The following is a description of a gene set: Mouse Gene Set: GOBP_REGULATION_OF_PROTEIN_TARGETING Any process that modulates the frequency, rate or extent of protein targeting. studied in species Mus musculus, and this is the list of marker genes: Gdi1, Nucb1, Kcne1, Mief2, Hras, Prnp, Bag4, Kcnb1, Mief1, Cacnb3, Adcy10 (NCBI Gene Id 73777), Srebf1, Inpp5k, Actr3, Cdkn2a, Pdcd5-ps, 4930550C14Rik (NCBI Gene Id 75311), Slc51b, Tomm70a, Fbxw7 (F-box and WD-40 domain protein 7), Fis1, Pak1, Lrrk2, Tent2, Tomm7 (NCBI Gene Id 66169), Atp5if1, Pdcd5, C2cd5, Siah3 (NCBI Gene Id 380918), Cib1 (calcium and integrin binding 1), Itgam, Prkaa1, Mtcl1, Dmtn, Ank3, Cdk5r1, Pink1, Usp17le, Stom, Arpc2, Bag3, Slc1a1, Chp1, Erbb2, Nol3, Gsk3a, Parl, Itgb1bp1, Cemip, Akt2, Ccl2, Tcaf1, Pdzk1, Mff, Fyn, Myo1c, Hpca, Hspa1l, Ptpn5, Ogt, Cdk5, Bnip3l, Grin2a